The following is a description of a gene set: Reactome Pathway: Downregulation of SMAD2/3:SMAD4 transcriptional activity This event has been computationally inferred from an event that has been demonstrated in another species.<p>The inference is based on the homology mapping from PANTHER. Briefly, reactions for which all involved PhysicalEntities (in input, output and catalyst) have a mapped orthologue/paralogue (for complexes at least 75% of components must have a mapping) are inferred to the other species. studied in species Mus musculus electronically inferred by orthology from the curated human pathway part of: Transcriptional activity of SMAD2/SMAD3:SMAD4 heterotrimer, and this is the list of marker genes: Ube2d1, Mapk3, Rps27a, Smurf2, Smad3, Atp1b4, Tgif1, Snw1, Ncor2, Ubb